The following is a description of a gene set: Genes predicted to be targets of miRBase v22 microRNA mmu_miR_6968_5p in miRDB v6.0 with MirTarget v4 prediction scores > 80 (high confidence targets). from publication Chen Y, Wang X (PMID 31504780) Mouse Gene Set: MIR_6968_5P studied in species Mus musculus, and this is the list of marker genes: Mknk2, Iqsec2, Dennd2a (DENN domain containing 2A), Asic1, Tmem26, Scrt1, Tfap2b, Ttyh3, Dmpk, Foxp4, Acr